Given this list of marker genes Adra2a, Camk2n1, Rac1, Myh9, Hcfc1, Crhr2, Adcy5, Sybu, Fto (FTO alpha-ketoglutarate dependent dioxygenase), Ndufaf2, Mup5, Pde1c, Efna5, Pde4c, Pim3, Ccdc186, Gpld1, Tbc1d1, Rbm4, Ptprn2 (protein tyrosine phosphatase receptor type N polypeptide 2), Cftr, Mup11, Slc2a2 (NCBI Gene Id 99576), Lepr, Abcg1, Gprc6a, Stx4a, Tunar, Ptprn, Rab11b, Lrp1, Crh, Gpr27 (G protein-coupled receptor 27), Atg7, Ppard, Mup3, Prkce, Map4k4, Mup4, Eny2 (NCBI Gene Id 72036), C1qtnf12, Mir410, Hmgcr, Pde3b, Pla2g6, Oxct1 (3-oxoacid CoA transferase 1), Ano1, Gpr39, Abcc8, Sidt2, Baiap3, Kif5b, Agt, Trpm4, Foxa2, Myt1, Cacna1e, Epha5, Dynll1, Mlxipl, Ptpmt1, Abca12, Tcf7l2, Mir130a, Lrp5, Pde8b, Rfx6, Ncoa6, Raf1, Tiam1, Sirt1, Ghrl, Mup2, Sri, Arrb1, Stxbp4, Mir200a, Fkbp1b, Brsk2, Mpc2, Birc5, Vsnl1, Nadk, Rab11fip2, Osbp (oxysterol binding protein), Bad, C2cd2l, Hif1a, Jagn1, Prkn, Ppp3cb, Pdx1 (NCBI Gene Id 18609), Cdk16, Adcy8, Zbed6, Piwil4, Trpm5, Gpr68, Gcg, Trpa1, Klf7, Nr1h4, Rab11fip5, Cltrn, Hmgn3, Ucp2, Nr1d1, Slc9b2 (solute carrier family 9, subfamily B (NHA2, cation proton antiporter 2), member 2), Cacna1d, Mup1, Selenot, here is a description of the gene set: species: Mus musculus Mouse Gene Set: GOBP_INSULIN_SECRETION_INVOLVED_IN_CELLULAR_RESPONSE_TO_GLUCOSE_STIMULUS The regulated release of proinsulin from secretory granules (B granules) in the B cells of the pancreas; accompanied by cleavage of proinsulin to form mature insulin, in response to a glucose stimulus.